The following is a description of a gene set: studied in species Homo sapiens Ulnar deviation of the 2nd finger Human Gene Set: HP_ULNAR_DEVIATION_OF_THE_2ND_FINGER Displacement of the 2nd (index) finger towards the ulnar side., and this is the list of marker genes: BMP2, PTRH2, HOXA13, TGDS, GDF5, ANKRD11, BMPR1B (bone morphogenetic protein receptor type 1B)